The following is a description of a gene set: species: Homo sapiens Genes up-regulated in comparison of dendritic cells (DC) stimulated with LPS (TLR4 agonist) at 8 h versus DCs stimulated with LPS (TLR4 agonist) and R848 for 8 h. Toll like receptors (TLRs) sense microbial products and initiate adaptive immune responses by activating dendritic cells (DCs). Since pathogens may contain several agonists we asked whether different TLRs may synergize in DC activation. We report that in human and mouse DC TLR3 or TLR4 potently synergize with TLR7, TLR8 or TLR9 in the induction of selected cytokine genes. Upon synergistic stimulation, IL-12, IL-23 and Delta-4 are induced at levels 50-100 fold higher than those induced by optimal concentrations of single agonists, leading to enhanced and sustained TH1 polarizing capacity. Using microarray analysis we show that only 1.5% of the transcripts induced by single TLR agonists are synergistically regulated by combinations of TLR4 and TLR8 agonists. These results identify a combinatorial code by which DCs discriminate pathogens and provide (suggest) a rationale to design adjuvants for TH1 responses. Series_overall_design: 3 untreated, 3 treated with LPS at 2h, 3 treated with LPS at 8h, 3 treated with R848 at 2h, 3 treated with R848 at 8h, 3 treated with LPS + R848 at 2h, 3 treated with LPS + R848 at 8h Human Gene Set: GSE2706_LPS_VS_R848_AND_LPS_8H_STIM_DC_UP from publication Napolitani G, Rinaldi A, Bertoni F, Sallusto F, Lanzavecchia A (PMID 15995707), and this is the list of marker genes: SLC8A1, FCER2, TRAPPC12, ENTREP3, TMEM45B, ERO1A, TTC7B, RRM1, EGR2, AUH, NFIL3, SLC49A4 (solute carrier family 49 member 4), AP2A2, BCO2, CTLA4, SAMD9 (NCBI Gene Id 54809), PCYT1B, SRSF4, SLC8B1, MRAS, KAT2B, TMEM106B, NKAPP1, CD46, ILK, EMP1, PARP9, MAD2L2, THEMIS2, CKAP5, ZNF341, TINF2, SLC25A41, HINT3, BMAL1, IFIT2, SH3PXD2A, PTPRA, NHLRC3, MYD88, RBMS1 (RNA binding motif single stranded interacting protein 1), SANBR (NCBI Gene Id 84542), MRE11, ABCB10, HK1, PPA2, KDM1B (NCBI Gene Id 254751), SNTB2, HAUS4, AGAP3, CCR1, ANAPC4, AIDA, RALB, TMEM140, GNAQ, STAT1, BATF2, ADD1, ECI2, ANKLE1, GLUL, TFCP2, ITFG1, ZFYVE26, PNPT1, PPP2R3A, KRTAP7-1, AMPH, CASP3, HSPA8, GMPR, ELAC2, CTSO, VPS26B, PPP1R21, ERMARD, SNX3, GNB4, POLR2E, TMEM164, PKIB, TRIM14, EIF4E3, SUSD1, RTCB, DDRGK1, STIMATE, GUCD1, GIMAP2, IL13RA1, GTPBP2, TNFSF10, TRIB2, PCNP (PEST proteolytic signal containing nuclear protein), PLCG2, NAGK, MYO1F, EPDR1, CENPL, USPL1, ANKFY1, CRACDL, SLC25A43, TOR4A, CUL4B, PHC2, YWHAH-AS1, ANKRD22, SP140L (SP140 nuclear body protein like), TMEM109, SLC16A3, PRDM14, UBTD2, CCM2, AHR, TMLHE, TRPC4AP, MAP2K6, LINC02035, MGST1, VPS26C, KIAA0930, DECR1 (2,4-dienoyl-CoA reductase 1), MCRIP2, PPP2R1A, MARCHF8, STX7, LTA4H, BLTP2, SAMD9L, RARB, PTTG1IP, SMAD7, CASP10, IL4I1, SLC26A11, GPAT3, SLC25A29, INTS10, DBIL5P, BRCC3, COMMD7, ADPRS, MICAL1 (microtubule associated monooxygenase, calponin and LIM domain containing 1), PARPBP, SAMHD1, MUSTN1, NAIP, SMARCAL1, MTHFD1, DOCK11, SHFL, NCOA1, ARHGEF6, RBM24, TOR1B, SLC44A1 (NCBI Gene Id 63942), MLLT6, BMPR2, NT5C2, ACTA2, LMNA, ZFP2, NOPCHAP1, CCNY, NSMAF, ZNF717, NCSTN, FECH, ZNF18, PPBP, DDHD2, DOP1B, TWF2, GLE1, RGL1, MEF2C, LHFPL2, ARHGAP30, OLFML2A (olfactomedin like 2A), RCAN3, GBP4, GLIPR2, DCAF17, ZDHHC21, VAMP5, SURF1, SPATA17, BAG1, ZNF230, SHCBP1, CECR3, GALNT16, CLSTN1, ATP6V1H, GTF2H2B, XAF1